Given this list of marker genes RNU4-2, IKZF1, PLA2G6, CAMTA1, ZNF365, SLC9A6, GCH1, SQSTM1, SPTBN1, NALCN, ARX, ANKLE2, SNAPC4, CERT1, UBE3A, SCN1B, OPTN, BCORL1, DDC, VPS13A, HPDL, TBX1, NRXN1, ALS2, NFIX, CHCHD10, ZEB2, AP4E1, SLC16A2, SCN1A, MED12, SYNGAP1, MTHFS, FBXO28 (NCBI Gene Id 23219), VAC14, DLAT, ERBB4, LNPK, TANGO2, CHAMP1, TAF15, RAB11B, SRPX2, AP4M1, VAPB, PI4KA, TNFSF4, GLE1, SPTSSA, DNM1L, PON2, HCRT, TUBB2B, SMARCA2, SCN2A, GPT2, LMNB2, PTS, CACNA1I, HLA-B, MRE11, ATP1A3, SHMT2, HDAC4, MED27, SNRPN, HLA-DRB1, FOXP1, PCDH19, EIF2S3, ITPR1, NEFH, PRPH, GLT8D1, TAF4, DCTN1, NEXMIF, SPART, GNS, PAK3, POU3F3, NONO, SLC25A12, AP4B1, UBQLN2, HNRNPA1, NAXD, DLK1, SH3TC2, FOXG1, PIGL, ZC4H2, MOG, TARDBP, ATRX, ZBTB11, SLC12A5, TREM2, GRIN2D, PDE10A, MEG3, HIVEP2, ATP7B, SLC1A4, TBK1, TSPOAP1, STRADA, GABBR2, SETD5, PON3, FUS, SOD1, ATP6AP2, GRIK2, PPARGC1A, HNRNPH2, SCN9A, KIF7, PMP22, CFAP410, TH, SLC9A7, MBD5, FIG4, ADGRG1 (NCBI Gene Id 9624), SATB1 (SATB homeobox 1), HERC1, POLR3B, TASP1, PCGF2, KIF15, GFM2, MECP2, HLA-DQB1, EXTL3, PTPA, PFN1, GABRG2, TTI1, GRIN2A, RTL1, OCA2, CTSH, CCNF, CHMP2B, MATR3, SATB2, POLR3A, AP4S1, CLDN11, ATP10A, NTNG2, DAO, FOXP2, ATXN2, VCP, DEAF1, FBLN1, PON1, KCNC2 (potassium voltage-gated channel subfamily C member 2), PRPS1, NAA20 (N-alpha-acetyltransferase 20, NatB catalytic subunit), QDPR, UNC13A, ANG, NEK1 (NCBI Gene Id 51037), ANXA11, SPEN, GABRA1, RSRC1, P2RY11, here is a description of the gene set: Excessive salivation Human Gene Set: HP_EXCESSIVE_SALIVATION Excessive production of saliva. species: Homo sapiens